Given this list of marker genes BEST4, CYB5RL, SLC26A10P, SLC39A14, SLC4A11, SLC4A9, CFTR, SLC26A3, BEST1, CA4, RHAG, SLC26A6 (NCBI Gene Id 65010), SLC26A7, SLC39A6, SLC39A8, SLC4A5, SLC4A7, SLC4A4, CYB5R4, SLC4A8, CYB5R1, SLC26A4, SLC4A3, SLC26A9, SLC26A2, SLC26A1, SLC26A8, SLC4A2, SLC26A5, BEST2, SLC39A10, SLC4A10 (NCBI Gene Id 57282), SLC4A1, CYB5R2, SLC39A5 (NCBI Gene Id 378941), SLC39A4, SLC39A12, here is a description of the gene set: Human Gene Set: GOBP_BICARBONATE_TRANSPORT studied in species Homo sapiens The directed movement of bicarbonate into, out of or within a cell, or between cells, by means of some agent such as a transporter or pore.